The following is a description of a gene set: Genes down-regulated in HeLa cells (cervical carcinoma) by trabectedin. from publication Gajate C, An F, Mollinedo F (PMID 12198119) studied in species Homo sapiens Human Gene Set: GAJATE_RESPONSE_TO_TRABECTEDIN_DN We have found that ecteinascidin-743 (ET-743) inhibited cell proliferation at 1-10 ng/ml, leading to S and G(2)/M arrest and subsequent apoptosis, and induced early apoptosis without previous cell cycle arrest at 10-100 ng/ml in cancer cells. ET-743-mediated apoptosis, did not involve Fas/CD95. ET-743 induced c-Jun NH(2)-terminal kinase (JNK) and caspase-3 activation, and JNK and caspase inhibition prevented ET-743-induced apoptosis. ET-743 failed to promote apoptosis in caspase-3-deficient MCF-7 cells, further implicating caspase-3 in its proapoptotic action. Overexpression of bcl-2 by gene transfer abrogated ET-743-induced apoptosis, but cells underwent cell cycle arrest. ET-743 triggered cytochrome c release from mitochondria that was inhibited by Bcl-2 overexpression. Inhibition of transcription or protein synthesis did not prevent ET-743-induced apoptosis, but abrogated ET-743-induced cell cycle arrest. Microarray analyses revealed changes in the expression of a small number of cell cycle-related genes (p21, GADD45A, cyclin G2, MCM5, and histones) that suggested their putative involvement in ET-743-induced cell cycle arrest. These data indicate that ET-743 is a very potent anticancer drug showing dose-dependent cytostatic and proapoptotic effects through activation of two different signaling pathways, namely a transcription-dependent pathway leading to cell cycle arrest and a transcription-independent route leading to rapid apoptosis that involves mitochondria, JNK, and caspase-3., and this is the list of marker genes: CCDC86, H1-10, STAG1, ARHGDIA (Rho GDP dissociation inhibitor alpha), GMDS, CDK14, TEAD4, MCM5, LRBA, ABCB6, CENPX, FARS2, PKP4, UTP20, E2F2, STX8, H4C11 (NCBI Gene Id 8363), TRIM16, DDX10, H4C3